Given this list of marker genes ZRSR2P1, ID2, CSTF1, EIF3J, NCOA3 (nuclear receptor coactivator 3), CCND1, NSMAF, GYPC (glycophorin C (Gerbich blood group)), SNRPA1, UBE2D2, GSTM3, ID2B, ING1, VCAN, TNFRSF11B, SLC2A1, TLE1, CITED2, MSX2, GJA1, SRP19, RPL27A, EDNRB, here is a description of the gene set: Genes up-regulated in NCCIT cell line (embryonic teratocarcinoma) after stimulation with WNT3A. BACKGROUND: Wnt signaling is implicated in many developmental decisions, including stem cell control, as well as in cancer. There are relatively few target genes known of the Wnt pathway. RESULTS: We have identified target genes of Wnt signaling using microarray technology and human embryonic carcinoma cells stimulated with active Wnt protein. The ~genes upregulated early after Wnt addition include the previously known Wnt targets Cyclin D1, MYC, ID2 and betaTRCP. The newly identified targets, which include MSX1, MSX2, Nucleophosmin, Follistatin, TLE/Groucho, Ubc4/5E2, CBP/P300, Frizzled and REST/NRSF, have important implications for understanding the roles of Wnts in development and cancer. The protein synthesis inhibitor cycloheximide blocks induction by Wnt, consistent with a requirement for newly synthesized beta-catenin protein prior to target gene activation. The promoters of nearly all the target genes we identified have putative TCF binding sites, and we show that the TCF binding site is required for induction of Follistatin. Several of the target genes have a cooperative response to a combination of Wnt and BMP. CONCLUSIONS: Wnt signaling activates genes that promote stem cell fate and inhibit cellular differentiation and regulates a remarkable number of genes involved in its own signaling system. from publication Willert J, Epping M, Pollack JR, Brown PO, Nusse R (PMID 12095419) studied in species Homo sapiens Human Gene Set: WILLERT_WNT_SIGNALING